The following is a description of a gene set: Genes upregulated in senescent cells: Senescence-associated secretory phenotype (SASP). species: Homo sapiens from publication Saul D, Kosinsky RL, Atkinson EJ, Doolittle ML, Zhang X, LeBrasseur NK, Pignolo RJ, Robbins PD, Niedernhofer LJ, Ikeno Y, Jurk D, Passos JF, Hickson LJ, Xue A, Monroe DG, Tchkonia T, Kirkland JL, Farr JN, Khosla S (PMID 35974106) Although cellular senescence drives multiple age-related co-morbidities through the senescence-associated secretory phenotype, in vivo senescent cell identification remains challenging. Here, we generate a gene set (SenMayo) and validate its enrichment in bone biopsies from two aged human cohorts. We further demonstrate reductions in SenMayo in bone following genetic clearance of senescent cells in mice and in adipose tissue from humans following pharmacological senescent cell clearance. We next use SenMayo to identify senescent hematopoietic or mesenchymal cells at the single cell level from human and murine bone marrow/bone scRNA-seq data. Thus, SenMayo identifies senescent cells across tissues and species with high fidelity. Using this senescence panel, we are able to characterize senescent cells at the single cell level and identify key intercellular signaling pathways. SenMayo also represents a potentially clinically applicable panel for monitoring senescent cell burden with aging and other conditions as well as in studies of senolytic drugs. Human Gene Set: SAUL_SEN_MAYO, and this is the list of marker genes: CCL26, IGFBP1, CXCR2, CD55, IGFBP5, VEGFA, EGFR (epidermal growth factor receptor), VEGFC, JUN, MMP14, RPS6KA5, CTNNB1, TNFRSF10C, CST4, TNFRSF1B, IGFBP2, ITGA2, PGF (placental growth factor), CXCL1, TUBGCP2, NAP1L4, AXL, MMP3, SCAMP4, SELPLG, CCL1, CXCL12, ICAM3, CD9, PIGF, HGF, IL6ST, MMP10, GMFG, CXCL2, CSF2RB, TNFRSF11B, VGF, IL1A, IL13, EREG, ANGPTL4, IGFBP3, GDF15, ANGPT1, IL18, CCL3, GEM, WNT16, IL32, PECAM1, SPX, KITLG, CCL5, PLAT (plasminogen activator, tissue type), PAPPA, HMGB1, LCP1, PTGER2, TIMP2, SERPINE1, CCL8, MIF, TNF, FAS, CCL2, IL6, CXCL10, EGF, EDN1, NRG1, CXCL8, C3, INHA, CCL16, IGFBP4, BEX3, CCL7, PLAUR, CCL13, WNT2, IL2, IQGAP2, IGF1, IL15 (NCBI Gene Id 3600), MMP1, CXCL16 (NCBI Gene Id 58191), ANG, CXCL3, ICAM1, AREG, PLAU, CCL4, ESM1, IL1B, ETS2, IGFBP6, PTGES, MMP9, TNFRSF1A, SERPINB4, FGF7, IL10, PTBP1, CSF1, ACVR1B (activin A receptor type 1B), FGF1, SPP1, SERPINE2, BMP6, SEMA3F, DKK1, IL7, IGFBP7, ITPKA, MMP2, MMP12, CCL24, BMP2, FGF2, CSF2, CTSB, CCL20 (C-C motif chemokine ligand 20), MMP13